Given this list of marker genes Rest, Pde8b, Bmp2, Atp1a1, Dkk3, Bmp5, here is a description of the gene set: species: Mus musculus Mouse Gene Set: GOBP_NEGATIVE_REGULATION_OF_STEROID_HORMONE_BIOSYNTHETIC_PROCESS Any process that decreases the frequency, rate or extent of the chemical reactions and pathways resulting in the formation of steroid hormones,compounds with a 1, 2, cyclopentanoperhydrophenanthrene nucleus that act as hormones.